The following is a description of a gene set: A pentameric complex that includes orthologues of human PIR121, Nap1, Abi, SCAR, and HSPC300 and regulates actin polymerization and/or depolymerization through small GTPase mediated signal transduction. Human Gene Set: GOCC_SCAR_COMPLEX studied in species Homo sapiens, and this is the list of marker genes: BRK1, WASF2, ABI2, NCKAP1L, WASF3, ABI3 (NCBI Gene Id 51225), ABI1, WASF1, CYFIP1, CYFIP2, NCKAP1